Given this list of marker genes Fcgr3, C3, Wasl, Becn1, Alkbh4, Clcn2, Abca1 (NCBI Gene Id 11303), Timd6, Arf1, Siglece, Cd300a, Megf10, F2rl1, Dppa1, Pparg, Chmp2a, Rab31, Gsn, Cdc42, Sh3bp1, Itgb2, Rhoa, Elmo1, Thbs1, Xkr4, Arhgap25, Ighg2b, Arhgap12, Ano6, Itga2, Spire1, Xkr7, Alox15, Abca7, Clec7a, Havcr1, Stap1, Nckap1l, Trem2, Fcer1g, Syt11, Appl2, Lbp, Rac1, Snx9, Gata2, Fnbp1l, Aurkb (NCBI Gene Id 20877), Fcgr1, Clcn3, Marco, Ager, Aif1, Snx18, Snx3, Fcho2, Spire2, Timd5, Timd4, Adgrb1, Cd36 (NCBI Gene Id 12491), Plcg2, Ighg1, Smurf1, Xkr8, Xkr6, Itgam, Snx33, Treml4, Myh9, Fcgr2b, Msr1, Sirpa, Timd2, Gulp1, Bin2, Hgs, here is a description of the gene set: The infolding of a membrane. Mouse Gene Set: GOBP_MEMBRANE_INVAGINATION studied in species Mus musculus